Given this list of marker genes CRY1, CCDC71L, YWHAZ, REV1, RBM12B, DMRTA1, GLCE, UBR5, UBE2W, PTPDC1, STRN3, SERTAD2, AGR3, SOST, ERO1B, CDK6, PCGF5, DPP8, PRRC1, SH3TC2, STRBP, CARF, BLOC1S2, SLC38A1, USP10, ARAP2, LEMD3, ORC4, ZNF236, XRN1, DPY19L1 (NCBI Gene Id 23333), MBNL3, B4GALT6, RANBP3L, SMC5, GAS1, PPP2R5E, MED13L, ZNF20, TP53INP1, CFAP61, TBC1D22B, FAM220A, SAMD8 (sterile alpha motif domain containing 8), VGLL3, DDA1, L2HGDH, SGMS1, TXNRD3, AGO2, ZNF681, PIK3R1, SLC9A1, SMC2, TRIP12, KCMF1, FZD1, MFAP2 (microfibril associated protein 2), TMEFF2, SLC16A7, TJP1, UBXN4, GABPB1, ELOVL4, RBM24, DENND1B, EVI5, ZMYM3, IKZF2, DUSP15, MCF2L2, AOX1, MSTN, PHC3 (polyhomeotic homolog 3), UGGT1, MCU, ABI1, FAT1, SNX16, GABRG1, LIN28B, G3BP1, G2E3, BDP1 (NCBI Gene Id 59278), KDM7A, PCDHB15, ITPRIPL2, CCND1, KDELR1, BNIP2, SMIM8, DNAJC19, TVP23C, CPNE8, YTHDF1, MEX3B, ATP2A2, DLEU7, SLC19A2, IGSF5, TOMM70, NHLH2, ZNF468, CBLL1, GTF2B, NAA15, PTPRZ1, DCAF12L1, RNF217, TFPI2, PURG, TTYH2, CAMSAP2, TOX, DAZ4, SLC17A2, FAM83B, FYTTD1, HNRNPR, RSBN1, MARCHF4, RP2, MANEA, USP42, PDE1A, NAMPT, FRS2, DYNC1LI2, MAPKAPK2, ICE2, TET3, PHACTR2, PFKFB2, TCF7L2, MED30, CCNA2, CREM, CNEP1R1, FAM241A, MEF2C, VEZF1, REDIC1, CPSF6, PAK2, ARID4A, DIMT1, ZFR, TMPRSS11F, ZNF148, DBI, SOS2, SAR1B, PLEKHM3, MCTS1, RBBP4, GTDC1, ZEB2, TRHDE, SKI, RIMKLB, PDE4D, PLD5, PDS5A, SLC4A10 (solute carrier family 4 member 10), CREBRF, ARHGAP29, DIP2B, DNMT3B, TIAL1, RECQL, ZC3H12C, ANLN, USP46, FAM171B, APPBP2, ARL5A, YIPF4, TIGD3, RGS13, SYT4, NET1, DHX32, ELAVL1, DAZ2, TAOK1, GGCX, TMEM41B, GPR63, FER, SYTL4, ETF1, LSM8, KPNA4, PPP2R2B, NSD2, PARP15, LPP, ZNF740, NEK7, NUP62CL, CRISP1, MTSS1, BTBD7, MBTD1, CXCR4, ACTR3B, ARL6IP5, ZNF750, CYP4V2, EYA3, HMGN1, MPZL1, AMFR, VCPIP1 (valosin containing protein interacting protein 1), RORA, ZDHHC21, ZSWIM6, SOCS5, COL1A1, ARL14EP, SLC10A4, LCOR, HDX, ADH7, PEX5L, BEND4, ZBED4, USP37, DUS4L, HNRNPF, MAP4 (microtubule associated protein 4), PTPRD (protein tyrosine phosphatase receptor type D), TVP23B, ANKRD28, XRN2, NEXMIF, NAPG, DAZ1, SEH1L, ROR1, RNF139, QKI, RANBP1, RAD54B, IGFBP3, ETNK1, ZNF382, CELF2 (NCBI Gene Id 10659), MARK1, USP38 (NCBI Gene Id 84640), CTNND1, NABP1, USP15, FSTL1, DPY30, MICU3, PLAC8L1, RPS6KA6, ELMOD2, ERBB2, HECTD2, SOX21, RBPJ, AAGAB, ATP2B4, KCTD12, CCDC73, DYNLT3, MED6, SORBS1, SECISBP2L, DAZ3, GORAB, GCLC, SNW1, MRPS11, GKAP1, DYRK1A, ARL6IP6, MOB1B, PARD3, HPS1, PRMT1, PPP6C, SUFU, KNTC1, CCNYL1, RBM47, CTDSPL2, IRAK2, PRPF6, MME, WDR44, ATRNL1, MCL1, HOXA3, ACVR1, SELENOI, BCOR, SH3GLB1, PTH2R, ST6GALNAC5 (NCBI Gene Id 81849), DYRK2, CCL3L3, EIF5A2, GABRB3, NKX2-1, SERINC3, RAB23, RPS6KA3, ASPH, HDAC4, GPC6, VAPA, IDE, FGD6, B3GAT1, ZNF280D, STK24, TMED2, HBEGF, C12orf75, PELI1, ABLIM2, PUS7, GNAI3, CD38, ACSL3, SUZ12, PRKCB, HIPK2, PDE10A, JADE3, CKAP2, PLEKHB2, TLDC2, TMEM135, PTBP3, MAP2, USP24, FYN, KIAA0408, PYGO1, CSNK1A1, SOX2, KLHL24, OAF, ICAM5, PPM1K, SCN9A, ZNF24, GPD2, SON, GPATCH2, FOS, SIDT2, GTF2I, STOX2, GSPT1, PDE7A, VKORC1L1, ZNF678, ATXN1, PHF14, GPR155, RNF19A, YTHDF3, QTRT2, ARK2N, ADAM17, ZNF322, FOXP2, SLC25A36, ANKRD13C, DICER1, SKIL, PNISR, BPTF, NAP1L1, GTF3C4, MPHOSPH9, B3GALT2, PCDH11X, FARP1, SUGT1, ZNF469 (zinc finger protein 469), MYC, SLC25A16, ADNP, UBE2D1, SLC12A2, CIP2A, CLDN11, NUFIP2, RPRD1A, DCLK1 (NCBI Gene Id 9201), GSE1 (Gse1 coiled-coil protein), FBXO11, PPP1CC, NRIP1, RASEF, AGBL3, CNST, PSD3, MCTP1, SOAT1, FBXL17, FOXN2, DNMT1, PIK3CA, HOXA9, ALCAM, PROSER1 (proline and serine rich 1), GTF2A1, RIMS1, SPTSSA, RIT2, LLGL2, STRA6, ZDBF2, ACBD5, STAG2, UBXN2B, ANKH, CECR2, UBN2, KRAS, RBM27, FLRT2, FBXL20, CPEB3, FBXW2, GNB4, FHDC1, RAF1, EPC1, CYP8B1, ANO4, TM7SF3, SLC25A44, RAC1 (Rac family small GTPase 1), TBL1X, FKBP5, CDKN1B, RPS3, CAMTA1, MAP2K4, DACT1, B3GALNT2, TMCO1, TUT4, C5orf24, SSH2, MAPK6, NAA50, TNPO1, DDX4, SSU72, PHIP, AAK1, SCAI, WASF1, N4BP2L2, SERPINB1, SREK1IP1, WNK3, ERBIN, IPMK, C21orf91, CADM2, COL4A1, ZNF704 (NCBI Gene Id 84737), LIG4, BPNT2, KCNQ5, ZNF365, SIAH2, MAP3K2, OAS3, TFDP1, AMER2, PRMT3, GABRB2 (gamma-aminobutyric acid type A receptor subunit beta2), MAFG, ZFHX3, ATOSA, ABHD13, SCG2, MBNL1, CCZ1B, MYEF2, CPEB4, SMARCA5 (SWI/SNF related, matrix associated, actin dependent regulator of chromatin, subfamily a, member 5), INPP5F, GAB1, PLAGL2 (PLAG1 like zinc finger 2), VPS4B, PRKCA, EGR3 (early growth response 3), RNF180, XPR1, RRP15, PUM2, ZBTB44, PRKAR1A (NCBI Gene Id 5573), ANKIB1, YBX1 (Y-box binding protein 1), CNOT7, TGDS, SKAP2, SYNCRIP, ZNF561, HYCC2, PRKAA2, ABCD4, SPOCK3, TBL1XR1, KANSL1L, MDFIC, UHMK1, SUB1, PPP4R2 (NCBI Gene Id 56340), COMMD9, MINDY2, AKAP5, EFEMP1, FAM177A1, SHPRH (SNF2 histone linker PHD RING helicase), LRATD2, TSC22D2, FMNL2, RYK (receptor like tyrosine kinase), AP1AR, RBMS3, DCUN1D4, SFPQ, PIGN, AEBP2, NTF3, CNTNAP2, PRSS35, PSMA1, FGFR3, APH1A, PAN3, AVL9, PGR, FERMT2, ABCA5, HIF1A, EMC1, KCNJ2, CYP2U1 (NCBI Gene Id 113612), SNRPD1, SLC7A11, RNGTT, C2orf49, SYT1, TC2N, SCYL2, RSPRY1, GRIA2, USP53, TOX3, P3R3URF-PIK3R3, SLC23A2, ACOT2, MYBL1 (NCBI Gene Id 649850), UFM1, HOXA5 (homeobox A5), MOSPD1, SLCO5A1, TLNRD1, IQGAP2, ARHGAP32, NCOR1, ASAP2, TBP, PTPRK, COA5, ARID1A, ARFGEF3, ZNF706, MOSMO, FSBP, SRFBP1, FRMD5, RC3H1 (ring finger and CCCH-type domains 1), PTPN5, STARD4, OTUD7B, CD47, INPP4A, ZFAND5, ZYG11B, BACE1 (NCBI Gene Id 23621), ZEB1, SLC30A7, ESRP1, SPICE1, DCP1A, CCZ1, DCBLD2, ROBO1, MMD, CLGN, UBAC2, GNL3L, OSBPL8, NPM1, DLG1, MAML3, ZNF652, BNIP5, AZIN1, AGPS, EXOSC9, APPL1, PAG1, PTBP2, EREG, INO80D, NOVA1, USP13, SLC2A13, NOTCH2, ACVR2B, SMIM13, NIN, AHSA2P, ADGRE2, DTNA, SOCS6, YES1, PHF20L1, FGF12, SLC4A7, KIAA1210, NOL4, DAG1, IGF2BP3, IFT56, DIS3L2, USP49, ZDHHC17, KLHL15, KMT2D, ADGRB3, FBXO8, ANO5, MED1, MMADHC, TAF5, BRD10, AKR1D1, HYCC1, ACVR1C, LZIC, FBXO43, ZNF326, TNRC6B, YIPF6, MMGT1, DCDC2, PPP4R3A, SLC35D1, PDS5B, SBSPON, ATF1, LIN7C (lin-7 homolog C, crumbs cell polarity complex component), UTRN, KDM5B, TMEM64, TRPC1, TRIM36, ETS1, MCC, ST6GAL1, ZNF682, PIK3R3, ARGLU1, CREB1, RPL34, TGFBR1 (NCBI Gene Id 7046), NANOGNB (NCBI Gene Id 360030), SOX6, ANKS1A, ZNF367, ING3, SMURF2, WDR37, NR2C2, RBBP8, MAPK8, GABBR2, IRX2, IGFBPL1, B4GALT4, PLPPR4, BAG5, HDAC9, MTCL3, PALM2AKAP2, SP4 (NCBI Gene Id 6671), PSIP1 (NCBI Gene Id 93428), SLC18B1, DNAJB5, ABHD2, MARCHF5, SETBP1 (NCBI Gene Id 284262), KLHL5, BCLAF3, KLHL11, PPFIA1, TMEM170A, CCNT1, CPEB1 (cytoplasmic polyadenylation element binding protein 1), GPC4, ZMPSTE24, EIF4B, GFPT1, TM2D3, JAK2, PCDH20, NAB1, BCAR1, SASS6, CDYL, CNOT6L, TGS1, MED12, DDX55, LHX9, TET2, SHISAL1, MAF (MAF bZIP transcription factor), MARCKSL1, PPP3CA, HMGXB4, SINHCAF, PRKCI, USP25, VASP, DCK, NFYA, NPM3 (NCBI Gene Id 63295), NLGN1 (neuroligin 1), FAM169A, HERPUD2, EPG5 (NCBI Gene Id 654033), AFF1, TTC14, PM20D2, ATL3, TRIM33, VPS13C, DTD1, ERGIC2, LIN7A, GNG2, MIB1, DCAF17, SPIRE1, ZNF609, TMEM50A, FZD3, UBE2H, COQ10A, MED13, PKD2, FLI1, ZBTB2, THSD7B, CDK17, ATF7IP, ZNF562, TMPO (thymopoietin), RAB3C (RAB3C, member RAS oncogene family), OXGR1, LPCAT2, PPAT (phosphoribosyl pyrophosphate amidotransferase), AFAP1, GABRA4, here is a description of the gene set: species: Homo sapiens from publication Chen Y, Wang X (PMID 31504780) Human Gene Set: MIR548AH_3P_MIR548AM_3P Genes predicted to be targets of miRBase v22 microRNA hsa-miR-548ah-3p, hsa-miR-548am-3p in miRDB v6.0 with MirTarget v4 prediction scores > 80 (high confidence targets).